Given this list of marker genes TPCN1, CNGA3, RYR1, AQP1, TRPA1, CNGB1, CNGA1, TRPV1, ITPR3, MCOLN2, TRPM2, PKD2, BEST2, CNGA4, HCN1, MCOLN3, HCN4, HCN2, KCNA10, RYR3, CNGA2, ITPR2, TPCN2, CFTR, ITPR1, CNGB3, RYR2, MCOLN1, BNIP1, here is a description of the gene set: Human Gene Set: GOMF_INTRACELLULARLY_LIGAND_GATED_MONOATOMIC_ION_CHANNEL_ACTIVITY Enables the transmembrane transfer of an ion by a channel that opens when a specific intracellular ligand has been bound by the channel complex or one of its constituent parts. species: Homo sapiens